The following is a description of a gene set: The presence of xanthomas (intra-and extra-cellular accumulations of cholesterol) extensor tendons (typically over knuckles, Achilles tendon, knee, and elbows). Human Gene Set: HP_TENDON_XANTHOMATOSIS Tendon xanthomatosis species: Homo sapiens, and this is the list of marker genes: APOB, LDLRAP1, TTPA, ABCG8, APOE, ABCG5, APOA2, PCSK9, LDLR, CYP27A1, PPP1R17, GHR, EPHX2 (epoxide hydrolase 2), APOA1